The following is a description of a gene set: Shigella OspG to TNF-NFKB signaling pathway. Pathway ID: N00942. Pathway type: Pathogen. Pathway class: nt06516 TNF signaling. Pathway Definition from KEGG: OspG -| (UBE2D2+(RBX1+CUL1+SKP1)+FBXW1/11) -> NFKBIA studied in species Homo sapiens Human Gene Set: KEGG_MEDICUS_PATHOGEN_SHIGELLA_OSPG_TO_TNF_NFKB_SIGNALING_PATHWAY, and this is the list of marker genes: CUL1, RBX1, UBE2D2, SKP1, NFKBIA, FBXW11, BTRC